The following is a description of a gene set: Any process that modulates the frequency, rate or extent of the activity of the Wnt signal transduction pathway. studied in species Mus musculus Mouse Gene Set: GOBP_REGULATION_OF_WNT_SIGNALING_PATHWAY, and this is the list of marker genes: Sdhaf2, Tnks2, Zfp703, Ankrd66, Lgr5, Tmem170b, Rnf220, Ccnyl1, Abl1, Folr1, Ttc21b, Lrrk1, Lrrk2, Isl1, Potefam3b, Bicc1, Ptpro, Fermt1, Prickle1, Nppa, Foxl1, Tmem237, Dact2, Shh, Cyld, Lrp4, Trpm4, Ctnnbip1, Egr1, Amfr, Stk3, Lrp1, Nphp4, Tsc2, Gid8, Sox7, Hic1, Rnf43, Tax1bp3, Rbms3, Tle4, Prkn, Draxin, Mcc, Lypd6, Barx1, Limd1, Cer1, Tpbgl, Rnf14, Rapgef1, Fzd9, Frmd8, Mllt3, Sostdc1, Ppm1b, Hnf1a, Csnk1g2, Csnk1d, Amer3, Rack1, Gprc5b, Wnt5a, Egf, Gsk3b, Csnk2a1, Ctnnd2, Peg12, Tmem132a, Vgll4, Grb10, 2210016L21Rik, Lats1, Atp6v0c, Nkd2, Smad3, Vangl2, Stk11, Ccar2, Dkk2, Hdac1, Cdh3, Nfkb1, Atp6ap2, Emd, Daam2, Lmx1a, Pin1rt1, Rbpj, Dlx5, Ubac2, Map3k1, Sfrp2, Amer1, Hdac2, Lrp6, Wwtr1, Dkk3, Rps12, Asb3, Dab2ip, Ptpru, Egfr, Tbl1x, Dcdc2a, Fzd7, Klf15, Snx3, Cav1 (caveolin 1, caveolae protein), Dab2, Tmem88b, Wwox, Nxn, Sema5a, Macf1, Usp34, Abl2, Adnp, Disc1, Fgfr2, Mesp1 (mesoderm posterior 1), Sox9, Znrf3, Csnk1a1, Ift20, Xiap, Fgf10, Tle1 (transducin-like enhancer of split 1), Bmal1, Wls, Tmem88, Dkkl1, Prdm15, Fgf2, Lmbr1l, Hhex, Ctnnb1, Hnf1b, Sfrp5, Ddit3, Wnt3a, Aida, Tmem198b, Ruvbl2, Shisa3, Tbx18, Wnt10b, Dapk3, Itga3, Tcf7l2, Ruvbl1, Cdc73, Trabd2b, Reck, Wif1, Sost, Zranb1, Foxo1, Fzd6, Grem1, Sox2, Cxxc4, Apc2 (NCBI Gene Id 97679), Ccn4, Gpc5, Usp8, Tgfb1, Mks1, Ror2, Ctdnep1, Gpc3, Col1a1, Tnn, Plekha4, Smad4 (SMAD family member 4), Lzts2, Sbno1, Mdfic, Tert, Thra, Lats2, Tle2, Sox13, Dixdc1, Gli1, Vps35, Sfrp1, Spin1, Gnaq, Ppp2r3a, Sulf1, Foxo3, Nrarp (Notch-regulated ankyrin repeat protein), Ddx3x, Six3, Kank1, Ppm1a, Dkk1, Wnt3, Nfatc4, Csnk1g3, Ilk, Gli3, Smarca4, Sulf2, Hmga2, Sox17, Mesd, Tsku, Apcdd1, Amer2, Tmem9, Ppm1n, Chd8, Sox4, Atp6v1c2, Rspo3, Rspo4, G3bp1, Mdk, Axin2, Tlr2, Tmem131l (transmembrane 131 like), Ankrd6, Jade1, Zeb2, Kremen1, Otulin, Tle6, Csnk1g1, Sox10, Invs, Sall1, Gsdma3, Apoe, Nog, Wnt5b, Tnfaip3, Hm629797, Eda, Nkx2-5, Notch1, Mir154, Crbn, Kpna1, Depdc1b, Mad2l2, Tle5, Gsc, Tmem198, Dact3, Vcp, Fzd1, Bmp2, Alpk2 (NCBI Gene Id 225639), Psen1, Lgr4, Sfrp4, Pin1, Tbl1xr1, Wnk2, Cby1, Otud5, Scyl2, Ccdc88c, Mbd2, Potefam3a, Ube2b, Tnks, Cdh2, Nphp3, Ubr5, Ccdc134, Nle1, Plpp3, Nkd1, Tle3, Cthrc1, Axin1, Spef1, Rnf213, Fuz, Src, Usp47, Nlk, Mapk14, Shisa2, Ccny, Lgr6, Yap1, Aspm, Dkk4, Adgra2, Fgfr3, Sox30, Asb15, Ptk7, Mdfic2, Pfdn5, Csnk1e, Shisa6, Tmem64, Pbxip1, Scel, Zbed3, Gsk3a, Tpbg, Ctnnd1, Caprin2 (caprin family member 2), Snai2, Bambi, Frat1, Ift80, Wnt11, Spin4, Stk4, Frzb, Jrk, Mdfi, Rspo2, Nherf1, Siah2, App, Rspo1, Tiam1, Apc, Gskip, D1Pas1, Cdk14, Lbx2, Rnf146, Tle7, Fam53b, Cdh1, Cmah, Wnk1 (WNK lysine deficient protein kinase 1), Lef1, Btrc, Dact1, Notum, Lect2, Fgf9